Given this list of marker genes IL12B, HCAR3, LINC01138, IPCEF1, MMP7, TIFA, STEAP4, FFAR2, TANK, SDC4, RND1, PTAFR, EPM2AIP1, RAB21, SOD2, TNF, NFKBIZ, SAMSN1, BAZ1A, PSMA6, OASL, NIN, TNFAIP6, AQP9, PDSS1, ANKRD33B, KCNJ2, ZBTB10, GRAMD1A, NAB1, HCK, SPECC1L, CXCL8, ITGB8, PMAIP1, BIRC3, CLCF1, PELI1, TNIP3, PLXNC1, CT75, SLC2A6, PNRC1, EIF1B, EBI3, RIPK2, CYRIA, DRAM1, NFKBIA, CREBL2, OAZ2, TAGAP, SAV1, IRAK2, SUSD6, G0S2 (G0/G1 switch 2), SERPINB8, PNPLA1, OSR2, IL36G, ADA, PI4K2B, HS3ST3B1, TARP, C1orf122, HNRNPC, CLEC4E, RBM17, CCL23, STX11, SFR1, ZC3H12A, GADD45A (NCBI Gene Id 1647), PLAC8, RNF19B, RAPGEF2, CSF3, E2F7, IL6ST-DT, CD274, IL1B, IL23A, RHOF, LINC00528, ACOD1, CCL4, CD83, PLK3, BCL2A1, TP53INP1, XBP1, CD40, PTX3, PTGS2, TNFAIP3, SLC1A2, MARCKS, IL1A, C11orf96, QKI (QKI, KH domain containing RNA binding), CLIC4, SESTD1, STAT5A, MAP3K4, HDGF (heparin binding growth factor), FOXN2, TAOK3, ANO5, CENPU, MBNL1-AS1, PTPRJ, SLC1A3, CXCL1, BTG3, LINC01465, CFLAR, FJX1, TMEM123, SNX10 (sorting nexin 10), PIM3, MIR3142HG, RCSD1, TRAF1 (NCBI Gene Id 7185), ADORA2A-AS1, IL15RA, RNF144B, ZC3HAV1, NFKB1, GPR132, GCH1, CCSER2, TMPO-AS1, ACVR2A (activin A receptor type 2A), PPM1K (NCBI Gene Id 152926), IFIH1, NBN, CXCL2, CCNB1, APOO, CDK1, NFE2L2 (NFE2 like bZIP transcription factor 2), RHOH, LINC01093, LDLR, IL10, FSCN1, TAB2, IL6, RAP2C, GIMAP5 (GTPase, IMAP family member 5), PIK3AP1, ICAM4, EHD1, PPP1R15B, DUSP2, ICAM1, SMCO4, SOCS3, SLC25A12, KCNA3, ACSL1, PILRA, PTTG1IP, TNFRSF10B, CCL20, AZIN1, TNFAIP2, TLR7, MAP3K8, TNFRSF9, PFKFB3, MTF1, PLEKHF2 (pleckstrin homology and FYVE domain containing 2), IFNGR2, TCF7L2, DENND5A, PSMD5, UGP2 (UDP-glucose pyrophosphorylase 2), DCUN1D3, RIN2, STK26, DNAJA1, IER3, SNX18, TNFAIP8, GTF3C6, FNBP1, MIR9-1HG, NAMPT, MIR3945HG, MCOLN2, NCOA4, GBP1, NOCT, BIRC2, SYNPO2, RHOU, NLRP3, RIPOR2, here is a description of the gene set: studied in species Homo sapiens Genes down-regulated in comparison of monocytes treated with anti-TREM1 versus monocytes treated with 5000 ng/ml LPS (TLR4 agonist). Human Gene Set: GSE9988_ANTI_TREM1_VS_LPS_MONOCYTE_DN TREM-1 is an orphan immunoreceptor expressed on monocytes, macrophages, and neutrophils. TREM-1 associates with and signals via the adapter protein DAP12/TYROBP, which contains an immunoreceptor tyrosine-based activation motif (ITAM). TREM-1 activation by receptor cross-linking is pro-inflammatory, and can amplify cellular responses to Toll-like receptor (TLR) ligands such as bacterial lipopolysaccharide (LPS). To investigate the cellular consequences of TREM-1 activation, we have characterized global gene expression changes in human monocytes in response to TREM-1 cross-linking in comparison to and combined with LPS. Both TREM-1 activation and LPS up-regulate chemokines, cytokines, matrix metalloproteases, and PTGS/COX2, consistent with a core inflammatory response. However, other immunomodulatory factors are selectively induced, including SPP1 and CSF1 (i.e., M-CSF) by TREM-1 activation and IL-23 and CSF3 (i.e., G-CSF) by LPS. Additionally, cross-talk between TREM-1 activation and LPS occurs on multiple levels. While synergy in GM-CSF protein production is reflected in commensurate mRNA abundance, comparable synergy in IL-1b protein production is not. TREM-1 activation also attenuates the induction of some LPS target genes, including those that encode IL-12 cytokine family subunits. Whereas positive TREM-1 outputs are abolished by the PI3K inhibitor wortmannin, this attenuation is largely PI3K-independent. These experiments provide a detailed analysis of the cellular consequences of TREM-1 activation, and highlight some of the complexity in signal integration between ITAM- and TLR-mediated signaling. from publication Dower K, Ellis DK, Saraf K, Jelinsky SA, Lin LL (PMID 18292579)